Given this list of marker genes SBF2, SCO2, GDAP1, COMP, TRAPPC11, SLC25A21, HARS1, AK9, CHRNB1, LAMB2 (NCBI Gene Id 3913), ACTA1, RPS17, TRIM2, RPS28, DCTN1, SALL4, SLC12A6, ADAMTS15, SLC5A6, RPS24, KIF1A (NCBI Gene Id 654843), AAAS, FGFR2, AGRN, RPS20, SLC39A13, GMPPA, RPL15, UBAP2L, SVBP, RAD51C, MB, KANSL1, CHRNE, RPL8, FBXO38, EIF4A3, HEATR3, MFN2, NEFL, MPZ, GNE, PNPLA2, TTN, ITPR3, NGLY1, KLHL9, HSPB3, SLC52A3, RPS19, GYG1, HINT1, RPL18, CHRND, MORC2, FBXW11, DOK7, ALS2, LRP4, TSR2, FLNC, BSCL2, COLQ, PLOD3, CADM3, RPL11, LMNA, SPTLC1, MPV17, STIM1, MARS1, CHRNA1, RPL35A, HOXA13, TIA1, SNUPN, SIGMAR1, NEB, TIMM8A, JAG1, RPS29, SPG11, RPL26, RTN2, POLG, GARS1, RPL9, REEP1, YARS1, RPS10, RYR1, IDUA, TK2 (NCBI Gene Id 7084), RPS27, RPS26, RPS15A, ADA2, FLNA, RPL35, TBX5, MATR3, COL13A1, PRX, RPL5, PMP22, MAP3K7, RAPSN, SQSTM1, EMILIN1, SCN4A, CAV3, BICD2 (NCBI Gene Id 23299), GJB1 (gap junction protein beta 1), MYH7, RPS7, TFG, MUSK, CHCHD10, GBF1, RPL31, PDK3, DYSF (dysferlin), FXN, LDB3, VCP, RPL27, GATA1, TRPV4, FGD4, here is a description of the gene set: studied in species Homo sapiens Abnormality of the musculature of the hand Human Gene Set: HP_ABNORMALITY_OF_THE_MUSCULATURE_OF_THE_HAND